The following is a description of a gene set: species: Mus musculus COMMD1 (previously known as MURR1) belongs to a novel family of proteins termed the copper metabolism gene MURR1 domain (COMMD) family. The 10 COMMD family members are well conserved between vertebrates, but the functions of most of the COMMD proteins are unknown. We recently established that COMMD1 is associated with the hepatic copper overload disorder copper toxicosis in Bedlington terriers. Recent in vitro studies indicate that COMMD1 has multiple functions, including sodium transport and NF-kappaB signaling. To elucidate the function of Commd1 in vivo, we generated homozygous Commd1 null (Commd1(-/-)) mice. Commd1(-/-) embryos died in utero between 9.5 and 10.5 days postcoitum (dpc), their development was generally retarded, and placenta vascularization was absent. Microarray analysis identified transcriptional upregulation of hypoxia-inducible factor 1 (HIF-1) target genes in 9.5-dpc Commd1(-/-) embryos compared to normal embryos, a feature that was associated with increased Hif-1alpha stability. Consistent with these observations, COMMD1 physically associates with HIF-1alpha and inhibits HIF-1alpha stability and HIF-1 transactivation in vitro. Thus, this study identifies COMMD1 as a novel regulator of HIF-1 activity and shows that Commd1 deficiency in mice leads to embryonic lethality associated with dysregulated placenta vascularization. Mouse Gene Set: VANDESLUIS_NORMAL_EMBRYOS_UP from publication van de Sluis B, Muller P, Duran K, Chen A, Groot AJ, Klomp LW, Liu PP, Wijmenga C (PMID 17371845) Genes up-regulated in normal 9.5 days post coitus (dpc) embryos compared to normal 8.5 dpc and 9.5 dpc embryos., and this is the list of marker genes: Etv2, Hesx1, Creb3l3, Ppfia2, Actbl2